Given this list of marker genes Agrn, Adarb1, Rhoa, Cntfr (NCBI Gene Id 12804), Mir124a-1, Map3k12, Clcf1, Atf2, Fadd, Zpr1, Rapsn, Vps54, Fas, Bcl2, Crlf1, Map2k7, Rock1, Nefl, Kcnb1, Map2k4, Erbb3, Spg11, Slc1a1, Musk (NCBI Gene Id 230243), Bag1, Bax, here is a description of the gene set: Mouse Gene Set: GOBP_MOTOR_NEURON_APOPTOTIC_PROCESS species: Mus musculus Any apoptotic process in a motor neuron, an efferent neuron that passes from the central nervous system or a ganglion toward or to a muscle and conducts an impulse that causes movement.